The following is a description of a gene set: Mouse Gene Set: GOMF_ADENYL_NUCLEOTIDE_BINDING Binding to an adenyl nucleotide, an adenosine esterified with (ortho)phosphate. studied in species Mus musculus, and this is the list of marker genes: Hmgcr, Prkcb, P2rx6, Me1 (malic enzyme 1, NADP(+)-dependent, cytosolic), Actr3b, Pdk3, Oas2, Plk1, Mpped2, Por, Mthfd1l, Ndufa13, Ddx27, Dnaja3, Pkn3, Cdkl3, Sik2, Adcy3, Nadk2, Rapgef4, Clcn6, Acss1, Tdrd9 (tudor domain containing 9), Aak1, Grk1, Rad54l (NCBI Gene Id 99991), Eif4a1, Hunk, Ttl, Rskr, Ak4 (adenylate kinase 4), Oasl2, Nek5, Csnk1a1, Atp11a, Pak1, Vps4a, Map4k5, Oas1a, Aldh5a1, Kif19a, Epha4, Cryz, Ak3, Epha5, Fmo1, Cfap45, Slc22a21, Tkfc, Naip1, Vwa8, Nt5c2, Musk, Rfc1, Atrx, Ddx11, Itpka, Cdk11b, Nlrp12, Jak3, Kif2a, Abcc12, Dhx9 (NCBI Gene Id 98320), Ube2m, Fgfr4, Pkn2, Rad50, Tdg-ps, Ciita, Actb, Dnaja4, Rad54l2, Pfkfb2, Gucy2c, Suclg2, Ube2ql1, Ddx28 (DEAD box helicase 28), Pde10a, Ube2k, Mief1, Trmu, Uck1, P2rx2, Tor1b, Styk1, Tars1, Kalrn, Aox1, Wars2, Bub1, Ddx21, Myo7a, Rad51d, Eprs1, Kit, Prkaa1, Mcm5, Spast, Nme3, Myh10, Pfkl, Acsm1, Ddx42, Prps2, Sult2a8, Palm3 (NCBI Gene Id 74337), Erbb3, Csk, Pik3c3, Gclc, Ephb2, Recql4, Chd6, Popdc2, Qdpr, Uck2, Dyrk2, Smarcal1, Abca4, Nod1 (nucleotide-binding oligomerization domain containing 1, NCBI Gene Id 232000), Chd8, Nme4, Prkdc, Mapk6, Pi4k2a, Sbk1, Pfkm, Msh3, Dph6, Pip4k2b, Pms2, Ttk, Kti12, Ube2d3, Cbr4, Gmps, Camk2d, Prkg2, Atp5f1a, Nnt, Clk2, Rapgef3, Papss2 (3'-phosphoadenosine 5'-phosphosulfate synthase 2), Gphn, Smc3, Ror1 (receptor tyrosine kinase-like orphan receptor 1), Ascc3, Cad, Ip6k1, Ube2l3, Rlig1, Entpd6, Kif1b, Yes1, Smchd1, Sult1c1, Nmnat3, Wars1, Lmtk2, Ptpa, Map3k6, Magi3, Ube2b, Ptk6, Lrrk2, Miox, Prkch, Itpkc, Nek2, Rimklb, Abcg2 (ATP binding cassette subfamily G member 2 (Junior blood group)), Map3k11, Actr3, Myh7b, Atp9b, Gss, Afg3l1, Kif11, Peak1, Rimkla, Hsd17b1, Stk32a, Vars1, Cdk7, Idh2, Map2k7, Abcd3, Pkmyt1, Pfas, Csnk2a1, Pnck (NCBI Gene Id 93843), Kif3b, Camkk1, Frk, Gucy2d, Bag5, Atp13a3, Csnk1d (casein kinase 1, delta), Ros1, Popdc3, Ddx52, Pdpk1, Hltf, Me2, Lonp2, Ddx39b, Afg3l2, Speg, Taok1, Guk1, Abca8a, Camk2g, Camkv, Kif3c, Map4k1, Msh4, Prkar2a, Fyn, Ddx24, Myo19, Cdk10, Epha7, Ube2q1, Bckdk, Tnk1, Rictor, Mcmdc2, Pgk1, Nuak1, Araf, Slk, Ripk1, Jak2, Prkcz, Cdk19, Nme2, Actbl2 (actin, beta-like 2), Acvr1c, Cdkl2, Srpk1, Dars2, Ckmt1, N4bp2, Pbp2, Dyrk4, Acsl1, Mertk, Sirt5 (NCBI Gene Id 69760), Pank2, Tent4a, Ephb6, Pik3r4, Prkca, Ckb, Stk19, Eif4a3, Stk-ps2, Aurkb, Mapk15, Tk1, Cars1, Dgkd, Etnk2, Upf1, Pip5kl1, Cdc42bpa, Selenoo, Abcc3, Pygm, Ddx1, Atp13a5, Flt1, Riok3, Pebp1, Tec, Ube2h, Cct6a, Nos3, Ip6k2, Pccb, Mars1, Acsl4, Nmnat1 (NCBI Gene Id 70553), Ube2t, Csnk1g1, Ino80, Rhobtb3, Pgs1, Rbks, Sirt1, Hspa1l, Myo7b, Pikfyve, Ifih1, Naip5, Sult2a4, Smc1a, Kif5a, Cdk8, Abcc10, Brsk1, Pfn1, Acly, Ttll13, Dyrk3, Pdgfrb, Pak2, Atp7b (NCBI Gene Id 11979), Mast4, Irak1, Gucy2f, Prps1 (phosphoribosyl pyrophosphate synthetase 1), Dstyk, Mcm3, Atp8b2, Abcc6, Dck, Trib3, Hspa14 (heat shock protein 14), Sbk2, Snrnp200, Orc4, Kif21b, Rnls, Myh3, Sult2a3, Pfkfb4, Adh7, Nlrc3, Khk, G3bp1, Dgkb, Map3k12, Smc4, Nlrp4b, Atp1a2, Tssk6, Mapk10, Acsbg1, Chst15, Srms, Dars1, Fer, Clcn7, Clcn5, Nmnat2, Abca1, Pars2, Nlrx1, Adcy4, Bag1, Mylk4, Pgd, Chd1, Ttbk1, Tssk2, Parp14, Abcb8, Fgr, Cdc42bpg, Naxd, Chuk, Ddx5, P2rx3, Aprt, Nars1, Wee2 (NCBI Gene Id 381759), Hars1, Stk25 (NCBI Gene Id 98522), Hspa5, Dnah3, Ror2, Ttll1, Tesk1, Spo11, Pak5, Acvrl1, Mapk9, Prag1, Cdk12, Sik1, Plk2, Abcb1b, Abl1, Vrk1, Atp2b2, Mapk12, Dclk2, Atp5f1b, Atad1, Stradb, Clpx, Map3k7, Npr2, Mapk3, Ephb4, Cdk6, Psmc5, Vcp, Chek2, Actr8, Erbb4, Itk, Pals1, Hk3, Mdh1, Wee1 (WEE 1 homolog 1 (S. pombe)), Actg2, Lrguk, Cct3, Ksr2, Sars1, Kdsr, Csnk1g3 (NCBI Gene Id 70425), Mcm9, Wnk2, Pik3cb, Ppip5k1, Ahcyl, Nlrp4e, Pip5k1b, Mmab, Rps6ka2, Strada, Sik3, Wrn, Sephs2 (NCBI Gene Id 20768), Cryl1, Naip2, Myh6, Abcg1, Slc22a5, Akap7, Pim1, Adcy2, Amhr2, Mtor, Nlrp4c, Pskh1 (protein serine kinase H1), Ube2z, Taok2, Ehd2, Rps6ka6, Kif9, Epha3, Hsd11b2, Spg7, Myh8, Nlrp9b (NLR family, pyrin domain containing 9B), Txk, Nudt6, Farsb, Smarca5, Ripk2, Ube2r2, Nagk, Nlrp6, Hcn3, Ube2i, Fmo2, Grpel1, Myh4, Chordc1, Ttll2, Nme1, Cdkl5, Ldha, Rars1, Mov10 (NCBI Gene Id 97060), Afg2a, Tent4b, Pstk, Dpyd, Acsm4, Abcb10, Cdk14, Paics, Prkcq, Afg1l, Acvr1b, Acss3, Nadk, Glyr1, Myo1e, Acsf2, St13, Dnah5, Scyl1 (NCBI Gene Id 98159), Irak3, Timm44, Kcnj1, Tor2a, Atp4a, Bag3, Flt3, Atp9a, Pkdcc, Tap2, P2rx5, Nlrp10, Uxs1, Mst1r, Slc19a1, Cyb5r3, Mast3, Dhcr7, Myo1h, Ckmt2, Pex1, Itpr1, Grhpr, Ttn, Hk1 (hexokinase 1), Fn3krp, Coasy, Vdac1, Ak5, Helz (helicase with zinc finger domain), Mapkapk2, Dguok, Ube2o, Akt1, Nlk, Aox2, Hspa12a, Grk4, Aarsd1, Me3, Atp1a1, Dclk3, Top1, Camk1g, Cnga4, Mapk11, Pi4ka, Aurka, Aldh2, Hspd1, Cybb, Pkm, Hspa9, Cdk5, Atp2a2, Prkd2, Fgfr3, Smarcad1, Nlrp3, Aox3, Map2k4, Acsl5, Rad51, Ahcy, Atp11b, Trp53rkb, Prkaca, Kif1c, Ddx3y, Mcm7, Clcn4, Lats2, Mapkapk3, Ddx25, Ercc2, Abce1, Sgk2, Dhx15, Atp2a1, Clcn3, Ak2, Abcb11, Prkd1, Map4k3 (NCBI Gene Id 78862), Nmrk1, Irak4, Psmc4, Iqca1, Prkar1a, Rfc5, Idh3g, Nlrp4f, Insrr, Msh5, Aldh1a3, Eef2k, Fdxr, Tnni3k, Lig4, Matk, Ddx4, Papola, Ptk2, Pik3ca, Eif2ak4, Ruvbl1, Shprh, Idnk, Map4k4, 4933405O20Rik, Csnk1e, Prkce, Hsd3b1, Myo3b (NCBI Gene Id 635238), Kif21a, Kifc1, Twf2, Nos1, Acvr2a, Fars2, Pgk2, Fgfr1, Cilk1, Eif4a2, Pnkp, Cct8 (NCBI Gene Id 12469), Actr2, Etnk1, Katnal1, Rad17, Nek9, Map3k1, Irak2, Helb, Orc5 (NCBI Gene Id 26429), Ddx56, Rfc4, Adck1, Setx, Pip4k2a, Gm7168, Abcf3, Gatc, Elp1, Aldh18a1, Cul9, Hspa4l, Hcn4, Myo1d, Kifc3, Ddx39a, Nlrp5, Hsd17b8, Iars2, Mastl, Dmpk, Map3k5, Ilk, H1f4, Atp10b, Abcg4, Acvr2b, Aqr, Abca9, Wnk3, Mast2, Tep1, Flad1, Cdk1, Mok, Dnah2, Ttll6, Cdk20, Atp2c1 (ATPase, Ca++-sequestering), Smc5, Tie1, Katnal2, Hacl1, Sphk1, Hkdc1, Asns, Ears2, Sirt6, Ankk1, Kif16b, Thrap3, Gatb, Abcc9, Naip6, Uckl1, Trap1, Crym, Ralbp1, Kif28, Pdk2 (NCBI Gene Id 18604), Nlrp1b, Pxk, Sirt2, Mcm8, Map3k21, Ube2n (NCBI Gene Id 93765), Enpp3, Trpm7, Blm, Mark2, Ulk2, Dync1h1, Cgas, Ercc3, Ern1, Mat2a, Papolb, Hfm1, Acsm5, Ttll5, Tars3, Prkcg, Map3k9, Smarca2, Hars2, Tlk2, Ehd4, Cdk13, Pak4, Map3k10, Cdk18, Rps6kb1, Dicer1, Mtrr, Stk32c, Uba6, Top2b, Adcy7, Hspa13, Myo16, Atp6v1b2, Aasdh, Fignl1, Cct5, Tssk3, Aurkc, Bcs1l, Rps6ka5, Braf (NCBI Gene Id 97330), Stk16, Grk3, Gart, Mtrex, Map3k13, Pip4k2c, Pak6, Npr1 (natriuretic peptide receptor 1), Sil1, Skic2, Pomk, Abcc8, Epha2, Abcc5, Src, Runx1, Magi1, Npm1, Cnbd2, Mvk, G6pdx, Ddx6, Nek7, Aspdh, Entpd8, Riok1, Tpk1, Ttll12, Trnt1, Fastk, Ikbkb, Ehd1, Atp8b1, Myo1a, Nat10, Vps4b, Uba5, Nrk, Fbp1, Limk2, Stkld1 (serine/threonine kinase-like domain containing 1), Map3k20, Cct4, Pdik1l, Nol9, Gars1, Nek3, Eif4a3l2, Snrk, Nsf, Cdkl1, Stk10, Nek10, Stk39, Farsa, Prkag3, Eif4g1, Enpp1, Myo5b, Cdk9, Fmo4, Bag2, Xrcc5, Dhx29, Dhx33, Atp7a (ATPase, copper transporting, alpha polypeptide), Dhx58, Chd2, D1Pas1, Slfnl1, Nek8, Ddx51, Glul, Papss1 (NCBI Gene Id 99599), Cmpk1, Hyou1, Zap70, Smok2a, Lyn, Cmpk2 (NCBI Gene Id 80594), Srr, Uba3, Gk2, Nwd1 (NACHT and WD repeat domain containing 1), Adh4, Grk6, Dhx34, Dnaja1, Myo1c, Ripk4, Atp1a4, Acacb, Htatip2, Hells, Adk, Kif24, Nubp1, Rfc2, Ube2d2a, Scyl2, Hcn1, Map3k4, Sult2a5, Akt3, Fn3k, Sirt7, Cat, Ube2frt, Kif13a, Pex6, Ret, Scyl3, Parp1, Akr1b8, Dync1li2, Dapk1, Ddx49, Hipk3, Ak8, Tssk1, Ddx17, Ube2d2b, Sting1, Vars2, Aldh9a1, Xylb, Atm, Acvr1, Rps6ka4, Chka, Pmvk, Sult1a1, Bves, Yme1l1, Syn2, Dgke, Nlrp14, Rad54b, Hadh, Recql, Ddx20, Lmtk3, Cenpe, Ide, H6pd, Nuak2, Abca13, Ppip5k2, Coq8a, Nim1k, Stk33, Sult2a2, Tm7sf2, Stk4, Clk3, Plk5, Galk2, Prkag2, Met, Bmpr1b, Map2k3, Glud1, Fkbp4, Oplah (5-oxoprolinase (ATP-hydrolysing)), Cct6b, Mcm2, Nadsyn1, Ctps1, Yars1, Sgk3, Kif20b, Ddx31, Fbh1, Katna1, Itm2c, Cps1, Eif2ak1, Entpd2, Ak6, Actr1b, Acsl3, Ube2d1, Smc2, Prkci, Ube2j2, Atp6v1b1, Cask, Phkg1, Dhx36, Map2k1, Bmpr1a, Dgkg, Kif15, Ddx59, Phgdh, Entpd3, Dgkz, Syn1, Erbb2, Ube2e3, Phkg2, Kdr, Lrrk1, Entpd1 (NCBI Gene Id 72476), Flt4, Dhx8 (DEAH-box helicase 8), Tlk1, Ube2f, Pif1, Abl2, Acsbg2, Abcg8, Map3k8, Abcg3, Qars1, Smok3b, Actg1, Msh6, Nod2, Ttll3 (NCBI Gene Id 101100), Recql5, Ulk3, Tars2, Ube2g1, Mapkapk5, Epha8, Cbr3, Tssk5, Atp8b3, Abcf1, Twnk, Trex1, Agap2, Hspa4, Dld, Ep400, D5Ertd579e, Grk5, Adck2, Ercc6l (excision repair cross-complementing rodent repair deficiency complementation group 6 like), Brip1, Ythdc2, Ntpcr, Ntrk2, Cdc42bpb, Dcakd, Ddx47, Nmrk2, Dyrk1a, Ube2l6, Melk, Gk5, Pank1, Limk1, Ippk, Kif20a, Slfn8, Mast1, Ehd3, Pip5k1c, Morc2a, Trip13, Hipk2, Atp11c (NCBI Gene Id 54668), Ehhadh, Idh3a, Atp10a, Hnrnpu, Oas3, Hsp90aa1, Map3k14, Ddx18, Slc12a4, Dhx40, Dnhd1, Prkar1b, Helz2, Fgfr2, Nlrc5 (NLR family, CARD domain containing 5), Tek, Map3k15, Abca2, Qrsl1, Slfn9, Fam20b, Ak1, Ldhb, Ptk7, Bcr, Chd9, Stk24, Hipk4, Ddx19a, Chek1, Kif17, Gapdh, Kif12, Stk11, Myo1f, Hspa8, Gsk3b, Slc27a5, Clk4, Eif2b2, Ksr1, Myo1g, Cdkl4, Hpgd, Tor3a, Stk38l, Pik3cd, Ripk3, Dqx1, Itpr2, Ctbp1, Atp2c2, Nvl, Smc6, Kifc2, Ttll10, Wnk1, Hipk1, Hsp90ab1, Hsph1, Pak3 (NCBI Gene Id 18481), Nlrp9a, Adcy8, Acsf3, Gne, Map2k5, Nlrp9c, Cdc34, Abcf2, Cacna1b, Tor1a, Rfk, Dna2, Atr, Camk4, Aacs, Shpk, Fcsk, Ube2w, Fpgs, Alpk1, Chd4, Aldh1a1, Rps6kl1, Sult2a1, Ddx41, Oxsr1, Pik3c2g, Mark3, Mark4, Wnk4, Cdk2, Trit1, Pim3, Akr1c21, Mark1, Dync2h1, Bbs12, P2rx7, Clpb, Myo5a, Hspa2, Sars2, Prkcd, Ola1, Hsp90b1, Acsm3, Hlcs, Hspa1a, Lig3, Caprin1, Lats1, Myo1b, Srpk2, Atp1a3, Kif7, Ndor1, Ppcs, Myo3a, Atp13a2, Bdh2, Dhfr, Obscn, Itpk1, Ddx55, Dcaf1, Dclk1, Lbr, Ddx54, Trpm6, Chd7, Kif3a, Myo15a, Acsl6, Kif2b, Syn3, Dus2, Atp8a2, Atp2b4, Tgfbr2, Carns1, Atad3a, Ipmk, Lars2, Myo9a, Fmo3, Pdgfra, Tor4a, Alpk3, Csf1r, Kif14, Camk1, Msh2, Rock2 (Rho-associated coiled-coil containing protein kinase 2), Fancm, Mkks, Abca5, Gm4922, Ube2s, Itpr3, Pygl, Nlrp4a, Ak7, Abca6, Abcd2, P2ry2, Kif1a, Sirt4, Pank4, Camk1d, Tbck, Pbk, Sgk1, Blk, Clp1, Apaf1, Mapk4, Kif4, Ltk, Pip5k1a, Tcp1, Agk, Plk3, Ube2g2, Nek11, Uba1, Bmpr2, Chd1l, Mylk3, Pdk1, Prkaa2, Plk4, Trpv1, Abcb7, Ppp5c, Abcd4, Xrcc3, Pde2a, Hspbp1, Mlkl, Map2k6, Kcnj11, Papolg, Atp8a1, Ddx10, P2rx1, Pkn1, Ddx3x, Trib1, Tex14 (NCBI Gene Id 97747), Tut1, Mars2, Abcb4, Tap1, Tgfbr1, Hspe1, Kif26b, Nos2, Myh14, Acot12, Dnah12, Eif2ak2, Ctps2, Renbp, Tk2, Ube2c, Ighmbp2, Cnga1, Mthfs, Adcy10 (adenylate cyclase 10), Gak, Cars2, Kcnab1, Tesk2, Hsd17b10, Camk2a, Ikbke (inhibitor of kappaB kinase epsilon), Hibadh (NCBI Gene Id 58875), Pim2, Myo6, Atp12a, Map2k2, Afg2b, Orc1, Pklr, Mvd, Swap70 (SWA-70 protein), Pask, Smarca4, Gucy2g, Mapk1, Slc27a2, Xrcc2, Dalrd3, Abca3, Morc2b, Psmc3, Bub1b, Aars1, Sphk2, Ddx46, Rock1, Rad51b, Abcc1, Hk2, Ndufv1, Dync1li1, Gsk3a, Chkb, Rps6kb2, Cct2, Rps6ka3, Pdxk, Myh1, Atp13a1, Dnaja2, G6pd2, Abcd1, Kif23, Pink1, Stk35, Ptk2b, Xrcc6, Myh9, Mtpap, Cftr, Abcb5, Nek4, Mink1 (NCBI Gene Id 50932), Pde1c, Helq, Alpk2, Iars1, Rrm1, Atad2, Rnf213, Ryr1, Pik3cg, Decr1, Bbs10, Ndufs2, Uba2, Dgkh (diacylglycerol kinase, eta), Bmp2k, Adcy5, Stk36, Akt2, Epha1, Oxgr1, Slc12a3, Bag4, Gck (glucokinase), Rtca, Runx2, Epha6, Eif4a3l1, Tyk2, Top2a, Ust, Pfkp, Jak1, Kcnj8, Yars2, Atad5, Ulk1, Gapdhs, Smok2b, Nlrc4, Vrk2, Ube2a, Aox4, Map3k2 (NCBI Gene Id 320245), Rad51c, Atp2b1, Mos, Iqca1l, Trio, Acaca, Rps6kc1, Btk, Tdg, Lars1, H1f7, Psmc6, Nrbp1, Camk2b (NCBI Gene Id 12323), Prkd3, Dnah8, Mthfr, Idh1, Mthfsl, P2ry1, Map4k2, Mapk7 (NCBI Gene Id 23939), Atp13a4, Abcc4, Nubp2, Csnk2a2, Hspa1b, Prkag1, Sephs1, Sirt3, Hsd11b1, Psmc2, Nme6, Prkx, Hadha, Acta1 (NCBI Gene Id 11459), Tent2, Abcb1a, Mat1a, Smarca1, Cdc7, Acsm2 (NCBI Gene Id 233799), Dhx32, Abca8b, Syk, Raf1, Nars2, Ttll4, Dmc1, Ddr2, Stk40, Ttbk2, Cnnm2, Chtf18, Zranb3, Brsk2, Srd5a1, Ercc6, Glyctk, Rngtt, Pdk4, Mak, Insr, Smc1b, Stard9, Itm2b, Atp6v1a, Ntrk1, Myo10, Mknk1, Ddr1, Hck, Rars2, Stk38, Nme7, Pde4a, Dgka (diacylglycerol kinase, alpha), Fes, Lonp1, Cdk16, Ddx50, Abca7, Ass1, Uba1y (ubiquitin-activating enzyme, Chr Y), Dhx30, Adcy6, Grk2, Pi4k2b, Prkar2b, Ruvbl2, Mapk13, Get3, Rapgef2, Lig1, Prkg1, Cdc123, Fam20c (FAM20C, golgi associated secretory pathway kinase), Acta2, Supv3l1, Abcb6, Tyro3, Mylk, Nek1, Ephb3, Rigi, Cdk15, Pi4kb, Gsr, Stk32b (NCBI Gene Id 72191), Cdc6, Gmds, Alk, Pfkfb1, Pank3, Kif22, Psmc1, Vrk3, Mov10l1, Kif27, Pde4d, Cnga2, Kars1, Mccc2, Runx3, Smok3a, Ficd, Mapk14, Wrnip1, Stk26, Fign, Mapk8, Aatk, 4921509C19Rik, Hspa12b (NCBI Gene Id 72630), Atp2a3, Uhmk1, Tbk1, Taf1, Gpd1l, Mlh1, Sucla2, Kif26a, Camkk2, Mcm6, Aars2, Prkacb, Sult2a7, Cdk17, Srxn1, Gk, Gucy2e, Cct7, Axl (AXL receptor tyrosine kinase), Ern2, Ube2e1, Abcb9, Ip6k3, Kif5b, Vdac2, Kcnj10, Nlrp1a, Rps6ka1, Dapk2, Csnk1g2, Sult2a6, Tssk4, Ulk4, Cerk, Stk17b, Ube2q2, Abca12, Egfr, Myh11, Baz1b, Haspin, Actr1a, Stk31, Mthfd1, Ckm, Tnik, Atp10d, Rtel1, Atp8b5, Mcm4, Grpel2, Sord, Ttll7 (NCBI Gene Id 70892), Idh3b, Ctbp2, Ttf2, Dapk3, Slfn5, Cit, Smg1, Bmx, Sbk3, Thg1l, Slc27a3, Abca17, Taok3, Nrbp2, Acss2, Cngb1, Mccc1, Stk3, Ephb1, Tdrd12, Galk1, Pik3c2a, Ube2e2, Nubpl, Myo9b, Dhx57, Ttll9, Adcy9, Cdk4, Dnah17, Dyrk1b, Pan3, Dgki, Adcy1, Ube2j1, Pcca, Polq, Clk1, P2ry4 (pyrimidinergic receptor P2Y, G-protein coupled, 4), Abcc2, Kif18b, Zgrf1, Riok2, Ttll8, Eif2ak3, P2rx4, Kif18a, Ube4b (NCBI Gene Id 80643), Mki67, Trpm4, Slc22a4, Kif2c, Rnasel, Abcg5 (ATP binding cassette subfamily G member 5), Tnk2 (NCBI Gene Id 53909), Prpf4b, Hcn2, Actc1, Nav3, Srpk3, Ercc6l2, Ryk, Igf1r, Trpv4, Myh7, Myo18a, Map3k19, Twf1, Gpd1, Ttll11, Lck, Ntrk3, Fmo5, Ugdh, Mocs3 (NCBI Gene Id 69372), Epha10, Pde4b, Mylk2, Kif5c, Dgkq, Map3k3, Nek6, Chd5, Coq8b, Dtymk, Dnah1, Mknk2, Pcx